The following is a description of a gene set: species: Mus musculus FOXP3 target genes up-regulated in T lymphocytes after stimulation with IL2. Human Gene Set: GAVIN_IL2_RESPONSIVE_FOXP3_TARGETS_UP from publication Gavin MA, Rasmussen JP, Fontenot JD, Vasta V, Manganiello VC, Beavo JA, Rudensky AY (PMID 17220874) Regulatory CD4+ T cells (Tr cells), the development of which is critically dependent on X-linked transcription factor Foxp3 (forkhead box P3), prevent self-destructive immune responses. Despite its important role, molecular and functional features conferred by Foxp3 to Tr precursor cells remain unknown. It has been suggested that Foxp3 expression is required for both survival of Tr precursors as well as their inability to produce interleukin (IL)-2 and independently proliferate after T-cell-receptor engagement, raising the possibility that such 'anergy' and Tr suppressive capacity are intimately linked. Here we show, by dissociating Foxp3-dependent features from those induced by the signals preceding and promoting its expression in mice, that the latter signals include several functional and transcriptional hallmarks of Tr cells. Although its function is required for Tr cell suppressor activity, Foxp3 to a large extent amplifies and fixes pre-established molecular features of Tr cells, including anergy and dependence on paracrine IL-2. Furthermore, Foxp3 solidifies Tr cell lineage stability through modification of cell surface and signalling molecules, resulting in adaptation to the signals required to induce and maintain Tr cells. This adaptation includes Foxp3-dependent repression of cyclic nucleotide phosphodiesterase 3B, affecting genes responsible for Tr cell homeostasis., and this is the list of marker genes: IL10RA, MCUB, IL2RB, SORD, STING1, ST14, RRAGD, SYPL1, KIF3B, FOXP3, ELOVL6, HIPK2, MCM7 (minichromosome maintenance complex component 7), ARMCX4, IL2RA, TNFRSF4, ZNF608, MAP3K8, GPR83